The following is a description of a gene set: Binding to nicotinamide-adenine dinucleotide phosphate, a coenzyme involved in many redox and biosynthetic reactions; binding may be to either the oxidized form, NADP+, or the reduced form, NADPH. Mouse Gene Set: GOMF_NADP_BINDING studied in species Mus musculus, and this is the list of marker genes: Fmo1, Lbr, Hibadh, Gapdh, Hmgcr, Nnt, Fmo3, Ndor1, Dhfr, Nos2, Cybb, Srd5a1, Gapdhs, Dhcr7 (NCBI Gene Id 13360), Gmds, Idh1, Gsr, Fmo5, Por (cytochrome p450 oxidoreductase), Fdxr (ferredoxin reductase, NCBI Gene Id 14149), Dus2, G6pdx, Akr1c21, Glyr1, Cryz, Kcnab1, Cbr3, Pgd, Dpyd, H6pd, Crym, Miox, Tm7sf2, Nos3, Me3, Fmo4, Aspdh, Decr1, Fmo2, Nos1, Me1, Hsd11b1, G6pd2, Grhpr, Akr1b8, Mthfr, Mtrr, Qdpr (quinoid dihydropteridine reductase), Cbr4, Kdsr, Hsd17b1, Cat